Given this list of marker genes Zdhhc8, Fezf2, Clcn3, Mir96, Elavl4, Slc6a3, Btbd9 (NCBI Gene Id 69375), Penk, Dbn1, Asl, Dlg4, Eps8, Spg11, Pex13, Adgrl3, Ulk4, Celsr1, Tbce, Drd4, Cntn1, Kcnj10, B4galt2, Park7 (Parkinson disease (autosomal recessive, early onset) 7, NCBI Gene Id 57320), Dmd, Glra1, Ddhd2, Atp2b2, Dpp4, Sptbn4, Adam22, Abca2, Mir23a, Hexb, Npy1r, Hipk2, Fig4, Reln, Hoxd10, Nlgn2, Ppt1, Kalrn, Hoxd9, Elp6, Cln8, Mapt (microtubule-associated protein tau), Aph1b, Cwh43, Ghsr, Vps35, Chat, Dab1, Npc1, Atg7, Trh, Fgf12, Slc1a1, Cdh23, Enpp1, Cntnap2, Zfp212, Nav2, Grm1, Aph1c, Zic1, Idua, Cacna1e, App, Uchl3, Ppp3cb, Gprin3, Cend1, Epha4, Ntan1, Gpr88, Nrg1, Adcy8, Ube3a, Pitx3, Id2, Etv5, Ctns, Chrna4, Apba2, Rcan2, Chrna3, Gbx1, Grm6 (glutamate receptor, metabotropic 6), Lsamp, Rnf170, Oprl1 (opioid receptor-like 1), Crbn, Olfm2, Hprt1, Gaa, Mup1, Vps13a, Zfhx3, Pln, Arrb2, Slc4a7, Pak6, Abl2, Lrrtm1, Mup2, Mcoln3, Ncor1, Adra1b, Atp7a, Spg21, Apoe, Slc18a2, Oprd1, Myg1, Ntf5, Oxr1, Tnr, Slc4a10, Atp1a3, Dbh, Slc25a46, Dmbx1, Pde1b, Kcnd2, Dscam, Ngf, Tmod1, Tal1, Glrb (NCBI Gene Id 99751), Hexa, Dmrt3, Wdr47, Gng7, Gria1, Grin2d, Qrfp, Nr3c2, Gpr52, Strn, Cacna1c, Drd3, Prkce, Tshr, Trmt1l, Alk, Uba6, Zmpste24, Minar2, Shank3, Bc1 (brain cytoplasmic RNA 1), Pafah1b1, Lgi4, Pbx3, Fkrp, Fzd4, Mta1, Grin2a, Pum1, Lmx1a, Ndufs4, Prex2, Sez6l, Sncg, Meis1, Grm5, Tmbim4, Klhl1, Apba1, Fgf14, Sez6, Fshr, Cstb, Slurp1, Drd1, Bsx, Oprk1, Otog, Npas2, Nms, Pcdh15, Gip, Foxa2 (forkhead box A2), Rasd2, Pak5, Fmr1, Git1, Rcan1, Aplp2, Htr2c, Pmp22 (peripheral myelin protein 22), Sobp, Naglu, Nr4a2, Mtor, Npas3, Ido1, Scn1a, Gpr37, Mc3r, Th, Cln6 (NCBI Gene Id 76524), Sez6l2, Astn1 (NCBI Gene Id 11899), Bahcc1, Zfp385a, Aldh1a3, Slitrk6, Fxn, Arcn1, Uchl1, Myo15a, Mecp2, Grn, Cacnb4, Ckap5, Ntsr1, Borcs7, Cxcl12, Abat, Selenop, Espn, Atp1a2, Abhd12, Scn8a, Adora2a, Snca, Efnb3, Fign, Adcy5, Avp, Calb1, Arrdc3, Ccnd2, Lmx1b, Inpp5f, Negr1, Gla, Tuba1a, Nkx2-1, Htt, Gad1, Hoxb8, Ciart, Myo5a, Mup11, Gnao1, Kcnma1, Chl1, Crhr1, Pten, Crh, Chd7, Rogdi, Chrnb2, En1, Slc22a5, Myo6 (myosin VI), Mup3, Gigyf2, Shank2, Atxn1, Psap, Mup5, Cacna1a, Mup4, Tsc1, Mapk10, Snap25, Gprc5b, Chrnb4, Lrrk2, Sod1, Axin1, Drd2, Ankfn1 (ankyrin-repeat and fibronectin type III domain containing 1), Ppp1r1b, Gmfb, Prkn, Agtpbp1, Cnp, Ncoa2, Cacna1b, Egr1, Htra2, Als2, Large1, Mir133a-1hg, Cntn2 (NCBI Gene Id 320300), Lhx1os, Sod2, Oprm1, Usp2, Grin1, Lepr, here is a description of the gene set: studied in species Mus musculus The specific movement from place to place of an organism in response to external or internal stimuli. Locomotion of a whole organism in a manner dependent upon some combination of that organism's internal state and external conditions. Mouse Gene Set: GOBP_LOCOMOTORY_BEHAVIOR